The following is a description of a gene set: part of: Regulation of TP53 Activity species: Homo sapiens Phosphorylation of TP53 (p53) at the N-terminal serine residues S15 and S20 plays a critical role in protein stabilization as phosphorylation at these sites interferes with binding of the ubiquitin ligase MDM2 to TP53. Several different kinases can phosphorylate TP53 at S15 and S20. In response to double strand DNA breaks, S15 is phosphorylated by ATM, and S20 by CHEK2. DNA damage or other types of genotoxic stress, such as stalled replication forks, can trigger ATR-mediated phosphorylation of TP53 at S15 and CHEK1-mediated phosphorylation of TP53 at S20. In response to various types of cell stress, NUAK1, CDK5, AMPK and TP53RK can phosphorylate TP53 at S15, while PLK3 (Xie, Wang et al. 2001, Xie, Wu et al. 2001) can phosphorylate TP53 at S20.<p>Phosphorylation of TP53 at serine residue S46 promotes transcription of TP53-regulated apoptotic genes rather than cell cycle arrest genes. Several kinases can phosphorylate S46 of TP53, including ATM-activated DYRK2, which, like TP53, is targeted for degradation by MDM2. TP53 is also phosphorylated at S46 by HIPK2 in the presence of the TP53 transcriptional target TP53INP1. CDK5, in addition to phosphorylating TP53 at S15, also phosphorylates it at S33 and S46, which promotes neuronal cell death.<p>MAPKAPK5 (PRAK) phosphorylates TP53 at serine residue S37, promoting cell cycle arrest and cellular senescence in response to oncogenic RAS signaling.<p>NUAK1 phosphorylates TP53 at S15 and S392, and phosphorylation at S392 may contribute to TP53-mediated transcriptional activation of cell cycle arrest genes. S392 of TP53 is also phosphorylated by the complex of casein kinase II (CK2) bound to the FACT complex, enhancing transcriptional activity of TP53 in response to UV irradiation.<p>The activity of TP53 is inhibited by phosphorylation at serine residue S315, which enhances MDM2 binding and degradation of TP53. S315 of TP53 is phosphorylated by Aurora kinase A (AURKA) and CDK2. Interaction with MDM2 and the consequent TP53 degradation is also increased by phosphorylation of TP53 threonine residue T55 by the transcription initiation factor complex TFIID.<p>Aurora kinase B (AURKB) has been shown to phosphorylate TP53 at serine residue S269 and threonine residue T284, which is possibly facilitated by the binding of the NIR co-repressor. AURKB-mediated phosphorylation was reported to inhibit TP53 transcriptional activity through an unknown mechanism. A putative direct interaction between TP53 and AURKB has also been described and linked to TP53 phosphorylation and S183, T211 and S215 and TP53 degradation. Reactome Pathway: Regulation of TP53 Activity through Phosphorylation, and this is the list of marker genes: NOC2L, RBBP8, TAF7, TAF10, RPA1, TAF9B, TP53RK, RMI1, NBN, TAF15, RFC4, CSNK2A2, MDM2, STK11, EXO1, PRKAA2, HIPK1, MRE11 (NCBI Gene Id 4361), PRKAG1, TAF8 (NCBI Gene Id 135763), RHNO1, TP53INP1, HUS1, RAD9A, SSRP1, RAD17, RAD9B, TAF13, RAD50, CSNK2B, TOP3A, TAF6, PRKAB2, TP53, ATR, PRKAG3, TAF3, PLK3, TBP, CHEK2, WRN, CDK5R1, PRKAA1, RPS27A, RAD1, TPX2, SUPT16H, AURKA, RMI2, TAF12, RPA2, MDM4 (NCBI Gene Id 4194), TAF1, HIPK2, UBC, RFC5, PIN1, CCNA1, RFC3, TAF4 (NCBI Gene Id 6874), MAPK11, MAPKAPK5, RPA3, TAF7L, RFC2, PRKAB1, CDK5, TAF5, DNA2, CSNK2A1, ATRIP, MAPK14, BLM, TAF1L, ATM, CCNA2, DYRK2, BRCA1, CDK2, CHEK1, BARD1, UBB, TAF9, UBA52, KAT5, PRKAG2, NUAK1, TAF2, TOPBP1, AURKB, TAF11, BRIP1, TAF4B